Given this list of marker genes MED25, RPL23, AR, RELA (NCBI Gene Id 5970), CCNT2, CTNNBIP1, AHR, TEAD2, STAT1, CDK9, MED6 (NCBI Gene Id 10001), MED1, SMAD4, TRERF1, GATA6, GATA2, NHLH2, THRB, GATA3, STAT6, HIF1A, RORA, ZBTB49, ZBTB8A, ATF7, MAP3K7, VGLL4, RARA, SIX1, GATA1 (NCBI Gene Id 2623), ZBTB17, CIT, SMAD3, TP53, PPARD, TERT, PGR, EPAS1, HAND2, TFAM, BEX1, CREB1, NR4A3, NFKB1, RUNX1, ESR1, EP300, CREBBP, LHX3, FLYWCH1, PPARA, here is a description of the gene set: Human Gene Set: GOMF_TRANSCRIPTION_COACTIVATOR_BINDING species: Homo sapiens Binding to a transcription coactivator, a protein involved in positive regulation of transcription via protein-protein interactions with transcription factors and other proteins that positively regulate transcription. Transcription coactivators do not bind DNA directly, but rather mediate protein-protein interactions between activating transcription factors and the basal transcription machinery.